The following is a description of a gene set: The directed movement of cholesterol, cholest-5-en-3-beta-ol, or cholesterol-containing compounds, by membrane-bounded vesicles. studied in species Mus musculus Mouse Gene Set: GOBP_VESICLE_MEDIATED_CHOLESTEROL_TRANSPORT, and this is the list of marker genes: Vps54, Tpcn2, Vps51, Vps52, Vps53, Arl8b, Syt7, Pip4k2a